The following is a description of a gene set: species: Homo sapiens Any process that results in a change in state or activity of a cell (in terms of movement, secretion, enzyme production, gene expression, etc.) as a result of a cGMP (cyclic GMP, guanosine 3',5'-cyclophosphate) stimulus. Human Gene Set: GOBP_CELLULAR_RESPONSE_TO_CGMP, and this is the list of marker genes: NPR2, HCN4, HCN2, RAPGEF2, PDE2A, PDE3A, SLC6A4